The following is a description of a gene set: species: Homo sapiens Episodic hypertension Human Gene Set: HP_EPISODIC_HYPERTENSION, and this is the list of marker genes: MAX, VHL, RET, LBX1, TMEM127